Given this list of marker genes HIVEP1, B4GALT5, SNORA17B, NFKBIA, GREB1 (NCBI Gene Id 9687), PLK3, TUBB2A, PKD2L1, PXDC1, SLC25A25, SGMS2, SLAMF7, TAP1 (transporter 1, ATP binding cassette subfamily B member), MAP2K3, NFKBIZ, INSIG1, C17orf58, CLDN1, RASSF5, SNHG15, LINC02796, LILRA5, USP12 (ubiquitin specific peptidase 12), IL1B, RSAD2, ZBTB43, IFIT2 (NCBI Gene Id 8375), PLAGL2, TNFAIP3, CELF1, NFKBID, NABP1, PPP1R15A, ISG15, HERC6, CSRNP1, TNFAIP8, SERPINB9, PLAUR, MARCKSL1 (NCBI Gene Id 65108), VPS37B, CXCL3, LYRM1, GBP1, IL10RA, CHST7, IL36G, ZC3H12C, FXYD6, RNF144B, MYO10, RGS1, PIM3, IL6, CRACR2B, MYO1G, CDCA4, EDN1, ESPL1, BAZ1A, CYB5D1, ICAM1, TNFAIP2, ZNF189, DUSP5, PRKAG2-AS2, BIRC3, CXCL10, SDC4, DRAM1, MIR155HG, NAT8, TP53BP2, GRINA, MIR3945HG, IL12B, BCL3, PIK3R5, TMEM88, MCOLN2, C15orf48, SFMBT2, KCNJ2, BTG1, NCF1C, IFIT3, TICAM1, KCTD4, ZC3H12A, IQCM, TNFSF15, RETREG1 (reticulophagy regulator 1), IRAK2, BTG2, UAP1, SPRED2, FSD1L, BTG3, MAFF, GALNT3, TNIP2, CLCF1, MT1E, HS3ST3B1, INHBA (NCBI Gene Id 3624), PMAIP1, ISG20, IL1A, EHD1, KDM6B, TNFAIP6, CMPK2, DNAAF1, GADD45A, MIR3142HG, BTBD19, NFKB1, PLEK, REL, BID, ACSL1, RAPGEF2, DGCR6L, MFSD2A, RAB3IP, RPS6KL1, TTYH2, GPR132, CYP27B1, H1-3, NEURL3, SLC7A1, ZBTB44-DT, PTPN1, DENND3, IRF8, TRAT1, EFNA1, CCL11, BCL10-AS1, MAP3K8, P2RX7, GEM, ZNF697, IL15RA, STX11, TP53INP2, NINJ1, APOBEC3A, NFKBIB, DCN, CCL5, TTN, CXCL1, CCRL2, STK40, SLC7A5, DEFB124, NR4A3, SOCS3, ARL5B, SHISA2 (shisa family member 2), CASQ2, LRRC32, CCL4, TRAF1, MIR22HG, PLEKHG2, MASTL, PTGER4, MAPK6 (NCBI Gene Id 5597), SERPINA12, WT1, GRHL1, DCUN1D3, CXCL2, LTA, GADD45B, MFHAS1, PTGS2, GCH1, SLC2A3, SIAH2, LINC03025, ALG13, DDX3Y, PSMA6, HROB, STAT4, ALOX15B, CFLAR, RILPL2, ZNF608, LILRB2, here is a description of the gene set: studied in species Homo sapiens Toll like receptors (TLRs) sense microbial products and initiate adaptive immune responses by activating dendritic cells (DCs). Since pathogens may contain several agonists we asked whether different TLRs may synergize in DC activation. We report that in human and mouse DC TLR3 or TLR4 potently synergize with TLR7, TLR8 or TLR9 in the induction of selected cytokine genes. Upon synergistic stimulation, IL-12, IL-23 and Delta-4 are induced at levels 50-100 fold higher than those induced by optimal concentrations of single agonists, leading to enhanced and sustained TH1 polarizing capacity. Using microarray analysis we show that only 1.5% of the transcripts induced by single TLR agonists are synergistically regulated by combinations of TLR4 and TLR8 agonists. These results identify a combinatorial code by which DCs discriminate pathogens and provide (suggest) a rationale to design adjuvants for TH1 responses. Series_overall_design: 3 untreated, 3 treated with LPS at 2h, 3 treated with LPS at 8h, 3 treated with R848 at 2h, 3 treated with R848 at 8h, 3 treated with LPS + R848 at 2h, 3 treated with LPS + R848 at 8h from publication Napolitani G, Rinaldi A, Bertoni F, Sallusto F, Lanzavecchia A (PMID 15995707) Human Gene Set: GSE2706_UNSTIM_VS_2H_R848_DC_DN Genes down-regulated in comparison of unstimulated dendritic cells (DC) at 0 h versus DCs stimulated with R848 for 2 h.